The following is a description of a gene set: part of: Defective homologous recombination repair (HRR) due to PALB2 loss of function Reactome Pathway: Defective HDR through Homologous Recombination Repair (HRR) due to PALB2 loss of BRCA1 binding function studied in species Homo sapiens Mutations in the N-terminal coiled-coil domain of PALB2 (amino acids 9-44), involved in self-interaction and BRCA1 binding, impair the interaction of PALB2 with BRCA1. Phosphorylation of PALB2 by ATR on serine residue S59 promotes BRCA1-PALB2 interaction and the localization of PALB2 to DNA damage sites. Mutations in the coiled-coil domain can also affect PALB2 self-interaction, recruitment to double-strand break sites, homologous recombination repair, and RAD51 foci formation. PALB2 missense mutants that do not bind to BRCA1 can still be recruited to DNA double-strand break repair (DSBR) sites, probably through interaction with other proteins involved in DSBR, but they are unable to restore efficient gene conversion in PALB2-deficient cells and they render cells hypersensitive to the DNA damaging agent mitomycin C. Some variants in this region are also sensitive to PARP inhibitors., and this is the list of marker genes: KAT5, RMI2, RAD51C, TOP3A, BRCA2, RAD51, BRIP1, RAD51AP1, ATM, PALB2, DNA2, RAD51D, NBN, WRN, MRE11, RAD51B, XRCC2, EXO1, BRCA1, RBBP8, RAD50, BARD1, BLM, SEM1, RMI1